The following is a description of a gene set: Mouse Gene Set: GOBP_NEGATIVE_REGULATION_OF_RECEPTOR_SIGNALING_PATHWAY_VIA_STAT studied in species Mus musculus Any process that stops, prevents or reduces the frequency, rate or extent of receptor signaling via STAT., and this is the list of marker genes: Inpp5f, Hgs, Pparg, Sh2b3, Hmga2, Adipor1, Socs1, Ptprc, Leprot, Socs3, Ggnbp2, Hnf4a, Parp14, Irf1, Cish, Dab1, Bcl3, Ptprd, Sac3d1, Gbp7, Tbx1, Cav1, Traf3ip1, Clec12b, Ptpn2, Socs2 (NCBI Gene Id 216233), Pibf1, Neurod1, Ptprt, Suz12, Nf2